Given this list of marker genes Cxcl10, Mia3, Jam2, Adam10, Padi2, Stk39, Msn, Wnk1, Spns2, Cxcl13, Adam8 (a disintegrin and metallopeptidase domain 8), Oxsr1, Madcam1, Tnfsf14, Klrk1, Gcsam, Slc8b1, Akt1, Ccr6, Il27ra, Pycard, Ripor2, Ccl7, Itgb3, Selenok, Wnt5a, Aire, Ccl12, Ecm1, Xcl1, Abl1, Il4, Aif1 (allograft inflammatory factor 1), Ripk3, Cd69, Tnfrsf14, Cd99l2, Tmem102, Tnfsf4, Ccr2, Fadd, Cd200r1, Abl2, Ccl5, P4hb, Cxcl14, Ccl3, Ascl2, Dock8, Cd200, Wasl, Nedd9, Med23, Adtrp, Ccl20, Gpr15lg, Apod, BC037156, Crk, Rhoa, Ccl21a, Lrch1, App, Stk10, Ptk2b, Crkl, Adam17, Itga4, Ccr7, Cxcl12, Lgals9, Spn, Coro1a, here is a description of the gene set: studied in species Mus musculus Any process that modulates the frequency, rate or extent of lymphocyte migration. Mouse Gene Set: GOBP_REGULATION_OF_LYMPHOCYTE_MIGRATION